Given this list of marker genes WWOX, SUMO1, TFAP2A, TFAP2D, UBE2I, KCTD1, TFAP2E (transcription factor AP-2 epsilon), TFAP2B, KCTD15, TFAP2C, here is a description of the gene set: Reactome Pathway: Negative regulation of activity of TFAP2 (AP-2) family transcription factors species: Homo sapiens Transcriptional activity of TFAP2 (AP-2) transcription factor family homo- and heterodimers in inhibited by binding of KCTD1 or KCTD15 to the AP-2 transactivation domain. Transcriptional activity of TFAP2A, TFAP2B and TFAP2C is also negatively regulated by SUMOylation mediated by UBE2I (UBC9). Binding of the tumor suppressor WWOX to TFAP2C inhibits TFAP2C translocation to the nucleus. Transcription of the TFAP2A gene may be inhibited by CREB and E2F1. part of: Transcriptional regulation by the AP-2 (TFAP2) family of transcription factors